Given this list of marker genes BBS7, VPS13B, RBM8A, RPL10, GPC4, BBS1, BBIP1, DCHS1, IFT74, TWIST1, RIPPLY2 (ripply transcriptional repressor 2), NEDD4L, TTC8, EZH2, FANCM, BCOR, FANCA, PORCN, KCNJ8, FGD1, BBS4, NEK1, DLX6, H4C9 (NCBI Gene Id 8294), ERCC4, BBS9 (Bardet-Biedl syndrome 9), NECTIN1, BBS5, ROR2, RIPK4, BMS1, GLI3, SMO, CHRNG, PALB2, PAX3, ARL6, KAT6A, BHLHA9, CKAP2L, FBXW4, KCTD1, GDF5, SEM1, SALL1, APC, FREM2, CDH11, RAD51, HOXA11, CEP19, PPP2R3C, HOXD13, IKBKG, LFNG, WNT7A, CDH3, IFT122, CDC45 (cell division cycle 45), SALL4, FLI1, BBS2, MESP2, SCAPER, SDCCAG8, NECTIN4, BRCA2, BMP4, CFAP418, CACNA1C, NEK9, VPS35L, NAA10, FGF10, NSDHL, MYH3, SOST, KIF7, SEMA5A, IFT172, SUZ12, MECOM, WNT5A (NCBI Gene Id 7474), TWIST2, REV3L, XRCC2, NSD1, GJA1, ZFX, NOG, EPS15L1, PIEZO2, FGFR2, FAT4, FANCF, DLL4, NPHP1, FGFR3, LRP4, BRIP1, FANCI, MKKS, CTNND1, ITGB4, MED25, FANCD2, CCDC22, ARL6IP6, DOCK6, ALDH1A2, SCLT1, ORC1, RBM10, UBE3A, FANCG, PIK3CA, MED12, WDPCP, IRF6, SPECC1L, RBPJ, FERMT1, FZD2, BBS10, IFT27, DLL3, MAB21L2 (mab-21 like 2), FANCB, BTRC, CCBE1, IFT52 (intraflagellar transport 52), ARHGAP31, FANCE, HDAC4, PTDSS1, WASHC5, PHGDH, CTCF, FRAS1 (Fraser extracellular matrix complex subunit 1), PLEC, BRCA1, WDR35, DHCR7, IFT43, GRIP1, ABCC9, GNA11, FGFR1, SLX4, RERE, UBE2T, RB1, DHODH, RAD51C, HES7, ESCO2, MKS1, EFNB1, PLXND1, BBS12, SHH, NOTCH1, AKT1, BAP1, PSAT1, OFD1, CHSY1, CTNND2, CDH1, ADAMTS3, EOGT, UBA2, GPC3, DPYSL5, DVL3, TCTN3, FANCL, TMEM53, TBX5, TRIM32, LMBR1, SMOC1, DVL1, PNPLA6, KIFBP, CHUK, SETBP1, RTTN, RAB23, NXN, LZTFL1, CPLANE1, MEGF8, FLNB, RFWD3, DSP, CEP290, JUP, SF3B4, WNT10B, WDR19, DLX5, MAD2L2 (mitotic arrest deficient 2 like 2), FANCC, TP63, here is a description of the gene set: Human Gene Set: HP_FINGER_SYNDACTYLY species: Homo sapiens Webbing or fusion of the fingers, involving soft parts only or including bone structure. Bony fusions are referred to as \bony\ Syndactyly if the fusion occurs in a radio-ulnar axis. Fusions of bones of the fingers in a proximo-distal axis are referred to as \Symphalangism\. Finger syndactyly